Given this list of marker genes FBLN1, CXCL13, CR2, CCL19, ACKR1, C3, PYY, CCL21, IGLV3-10, MYL9, here is a description of the gene set: Human Gene Set: MILICIC_FAMILIAL_ADENOMATOUS_POLYPOSIS_DN from publication Milicic A, Harrison LA, Goodlad RA, Hardy RG, Nicholson AM, Presz M, Sieber O, Santander S, Pringle JH, Mandir N, East P, Obszynska J, Sanders S, Piazuelo E, Shaw J, Harrison R, Tomlinson IP, McDonald SA, Wright NA, Jankowski JA (PMID 18829530) studied in species Homo sapiens P-cadherin is normally expressed in the basal layer of squamous epithelia and absent from the healthy intestine and colon. We have previously shown it to be expressed in all inflamed, hyperplastic, and dysplastic intestinal and colonic mucosa. This study aimed to better understand the mechanisms controlling the expression of P-cadherin and the biological effects of its ectopic presence in the intestine and colon. We investigated the CpG methylation status of the P-cadherin (CDH3) promoter and P-cadherin mRNA and protein expression in cases of familial and sporadic colorectal cancer (CRC). The CDH3 promoter was hypomethylated in colonic aberrant crypt foci, in CRC, and, occasionally, in the normal epithelium adjacent to cancer, demonstrating a potential field effect of cancerization. The hypomethylation was also associated with induction of P-cadherin expression in the neoplastic colon (P < 0.0001). We then created transgenic mice that overexpressed P-cadherin specifically in the intestinal and colonic epithelium under the liver fatty acid binding protein promoter. Forced ectopic expression of P-cadherin accompanied by indomethacin-induced inflammation resulted in a 3-fold higher crypt fission rate within the small and large intestines in the homozygous mice compared with the wild-type animals (P < 0.02). We conclude that epigenetic demethylation of the P-cadherin promoter in the human intestine permits its ectopic expression very early in the colorectal adenoma-carcinoma sequence and persists during invasive cancer. Induced P-cadherin expression, especially in mucosal damage, leads to an increased rate of crypt fission, a common feature of clonal expansion in gastrointestinal dysplasia. Top genes down-regulated in colon epithelium biopsies from FAP (familial adenomatous polyposis) patients with mutated APC.